The following is a description of a gene set: Human Gene Set: GOBP_RENAL_TUBULE_MORPHOGENESIS studied in species Homo sapiens The process in which the renal tubule is generated by specification of cell fate, through the maintenance of cell polarity, regulated cell proliferation and morphogenetic cell rearrangements, shape changes and growth. A renal tubule is a tube that filters, re-absorbs and secretes substances to rid an organism of waste and to play a role in fluid homeostasis., and this is the list of marker genes: GLI3, SALL1, TCF21, FGF8, OSR1, LGR4, SMAD4, IRX3, HES5, DCHS1, WNT6, BCL2, WNT11, MTSS1, FGF2, SIX4, HS3ST3B1, WNT9B, PBX1, SMO, TACSTD2, MAGED1, CITED1, WT1, HOXB7, CTNNBIP1, WNK4, NOG, HOXA11, ADAMTS16, HS2ST1, VEGFA, SOX8 (SRY-box transcription factor 8), HS3ST3A1, IRX1, GDNF, PKD1, HNF1B, AGT, IRX2, LHX1, GATA3 (GATA binding protein 3), HOXD11, GREB1L (NCBI Gene Id 80000), BMP4, PKD2, NPNT, AGTR2, FGF1, TGFB1, SIX2, KLHL3, COL4A1, WNT1, KIF26B, FOXD1, BMP2, MYC, WNT2B (Wnt family member 2B), LAMA5, SIX1, WNT4, SHH, TMEM59L, PAX8 (NCBI Gene Id 7849), LZTS2, GPC3, EYA1, GREM1, PAX2, SOX9, CTNNB1, DLG1, LGR5, MEF2C, AHI1, PTCH1, ILK, HES1, GZF1, C1orf54